The following is a description of a gene set: electronically inferred by orthology from the curated human pathway part of: Plasma lipoprotein remodeling This event has been computationally inferred from an event that has been demonstrated in another species.<p>The inference is based on the homology mapping from PANTHER. Briefly, reactions for which all involved PhysicalEntities (in input, output and catalyst) have a mapped orthologue/paralogue (for complexes at least 75% of components must have a mapping) are inferred to the other species. Reactome Pathway: Assembly of active LPL and LIPC lipase complexes studied in species Mus musculus, and this is the list of marker genes: Lmf1, Angptl3, Angptl4, Lpl, Gpihbp1, Pcsk5, Lipc